Given this list of marker genes CSPP1, POGZ, POLR3A, SF3B2, TNFRSF11A, RINT1, EBP, SOX9, NSDHL, GNS, RPS19, ACVR1, INPPL1, VANGL1, CLCN3, LBR, FN1, DDRGK1, KIAA0586, SIX6, PRKAR1A, SLC35D1, TRPV4, SOX2, SLC26A2, GLB1 (NCBI Gene Id 2720), NOTCH2, TCIRG1 (T cell immune regulator 1, ATPase H+ transporting V0 subunit a3), FLNB, ARSL, SUMF1, SLC35B2, COL2A1, FUZ, SLC29A3, COL11A1, here is a description of the gene set: Vertebral hypoplasia species: Homo sapiens Human Gene Set: HP_VERTEBRAL_HYPOPLASIA Small, underdeveloped vertebral bodies.